The following is a description of a gene set: Human Gene Set: GSE17721_CTRL_VS_LPS_2H_BMDC_DN studied in species Homo sapiens Genes down-regulated in comparison of control dendritic cells (DC) at 2 h versus those stimulated with LPS (TLR4 agonist) at 2 h. mouse primary BMDCs were stimulated with tlr ligands and gene expression changes were profiled on Affymetrix arrays from publication Amit I, Garber M, Chevrier N, Leite AP, Donner Y, Eisenhaure T, Guttman M, Grenier JK, Li W, Zuk O, Schubert LA, Birditt B, Shay T, Goren A, Zhang X, Smith Z, Deering R, McDonald RC, Cabili M, Bernstein BE, Rinn JL, Meissner A, Root DE, Hacohen N, Regev A (PMID 19729616), and this is the list of marker genes: PTPRZ1, NUDT9, APPBP2, PLSCR1 (phospholipid scramblase 1), COL19A1, CASP4, PSORS1C2, RNF2, MMP14, MMP17, MARCHF7, PPIF, SMC5, KRT35, DNAJB12, GYPC, ATF3, DENND2D, ENPP1, HLA-DRA, CLEC4E, P2RY14, FLNB, SPRYD7, MTDH, CDKN1A, FHL1, CAVIN3, SLAMF1, UGT8, MTPN, TIMP1, ROM1 (retinal outer segment membrane protein 1), INPP1, MLLT6, SQSTM1, NIBAN1, TSPAN9, ARTN, SLC17A1, FGD1, CEP164, FZD5, CYSTM1, FOXF2 (NCBI Gene Id 2295), TTC39C, KDM5C, TMCO3, GNAI1, CCDC120, TYW5, RRAS2, LIG3, SGTB, TBK1, ELL2, KRT1, POSTN, CHGA, UPP1, PON3, PLPP3, CALCR, ZNF131, EBI3, MYO5B, AP4B1, MAP2K4, SNX16, NFKBIA, DTNB, STAR (steroidogenic acute regulatory protein), CBX4, NR3C1, PTPRE, PRKCH, MAP3K8, RNF208, TSPAN33, TMCO5A (transmembrane and coiled-coil domains 5A), IL36A, NAA38, SLC38A3, SOX14, FASTKD5, FER, VCAN, PALLD, PLG, CXCL6, UBL7, UBE2O, ACSL1, VPREB1, DMTF1, CDR2, CADM3, CDV3, ST3GAL1, BHMT (betaine--homocysteine S-methyltransferase), CALCRL, CD38 (NCBI Gene Id 952), CALB1, PTPN23, MUL1, CHD1, ZIC4, PIP5KL1, CRYBG3, MXI1, FGF18, TNFRSF10A, PCM1, EMID1, HILPDA, CCL13, HELZ2, BMPR2, CCNG2, SLC41A1, RIBC1, CLCF1, EDEM1, IFIH1, ITGB3, VCAM1, OPA3, NFKB2, KBTBD2, CACNA1D, CCDC134, TUBB4A, ADORA2B, BTG3, PIAS2, DSPP, BLCAP, SAPCD1, GAPDHS, KLHL25, CSF1, MT2A, TYW1, SYNPO2, RAB3B, MOS, CCR3, ATRX, KMT5A, SRA1, MEF2A, LMO4, TAF7, MMP1, DSC3, SLC27A5, BDKRB2, ADHFE1, ZRSR2, WASHC3, LIF, SLC15A3, NEK1, ARHGAP17, PPBP, BCR, ARID5B, GNA13, BGN, KLHDC8A, PPP2R2D (protein phosphatase 2 regulatory subunit Bdelta), OLR1, CHIC2, BIRC3, RGL1, RARG, TNFRSF8, SUCO, TIMMDC1, SEMA6C, ZNG1B, ARG2 (NCBI Gene Id 384), SPAG4, TSC22D1, GALNS, IER2 (immediate early response 2), GSTK1, COL4A2, GDF5, TMEM39A, SAMSN1 (NCBI Gene Id 64092), CD40, HMGB4, CRLF3, GZMB, EPN3, DHX15, GRIN2C, GLIPR1, UBE2S